Given this list of marker genes CLCA1, PLK3, EGR1, JMJD6, FOS, EGFR, SERTAD1, ZNF264, CHMP4A, RAB5B, ETV5, JAG1, CDYL, EMP3, GPATCH1 (G-patch domain containing 1), here is a description of the gene set: Our objective was to establish an experimental model of a self-sustained and bistable extracellular signal-regulated kinase 1/2 (ERK1/2) signaling process. A single stimulation of cells with cytokines causes rapid ERK1/2 activation, which returns to baseline in 4 h. Repeated stimulation leads to sustained activation of ERK1/2 but not Jun N-terminal protein kinase (JNK), p38, or STAT6. The ERK1/2 activation lasts for 3 to 7 days and depends upon a positive-feedback mechanism involving Sprouty 2. Overexpression of Sprouty 2 induces, and its genetic deletion abrogates, ERK1/2 bistability. Sprouty 2 directly activates Fyn kinase, which then induces ERK1/2 activation. A genome-wide microarray analysis shows that the bistable phospho-ERK1/2 (pERK1/2) does not induce a high level of gene transcription. This is due to its nuclear exclusion and compartmentalization to Rab5+ endosomes. Cells with sustained endosomal pERK1/2 manifest resistance against growth factor withdrawal-induced cell death. They are primed for heightened cytokine production. Epithelial cells from cases of human asthma and from a mouse model of chronic asthma manifest increased pERK1/2, which is associated with Rab5+ endosomes. The increase in pERK1/2 was associated with a simultaneous increase in Sprouty 2 expression in these tissues. Thus, we have developed a cellular model of sustained ERK1/2 activation, which may provide a mechanistic understanding of self-sustained biological processes in chronic illnesses such as asthma. Human Gene Set: LIU_IL13_PRIMING_MODEL Genes up-regulated in BEAS-2B cells (bronchial epithelium) stimulated with IL13 on days 1 to 3, rested on days 4 and 5, and then restimulated on day 6 for 1 h before lysis (priming model). studied in species Homo sapiens from publication Liu W, Tundwal K, Liang Q, Goplen N, Rozario S, Quayum N, Gorska M, Wenzel S, Balzar S, Alam R (PMID 20123980)